Given this list of marker genes Gm14379, Ebp, Gm15257, Ssxb8, Gm26401, Maoa, Usp27x, Ssxb16, Cybb, Hdac6, B630019K06Rik, Gm9429, Gm14375, Gm14367, Sytl5, Gm14635, Rpl22-ps1, A230072C01Rik, Gm15256, Gm14504, Gm14883, Btbd35f27, Otc, Cypt1, Gata1, Csnk2a1-ps2, Gm15252, H2al1k, Gm9434, H2al1g (H2A histone family member L1G), Gm14509, Mir221, Cacna1f, Gm9436, Llph-ps2, Gm14349, Gm14370, Fthl17f, Suv39h1, Gm14485, Gm15028, Mycs, Gm6923, Timm17b, Gm5380, Gm14348, Gm14516, Gpkow, Gm14513, Smt3h2-ps, H2ap, Gm14864, Gm6798, Gm14530, 2010308F09Rik, Flicr, Ppp1r3f, H2al1j (H2A histone family member L1J), Gm6797, Fthl17-ps1, Fthl17b, Btbd35f7, Gpr82, Gpr34 (NCBI Gene Id 23890), Usp11, Ssxa1, Gm23628, Gm14450, H2al1h, Mir222, Gm16481 (NCBI Gene Id 675380), Atp6ap2, Gm22783, Gm5123, Spin2-ps9, Mid1ip1, Mir188, Gm14520, Ccdc22, Nudt10, Plp2, Was, Kcnd1, Gm14538, Dusp21, Rpl36-ps10, Gm14365, Gm25481, Ssxb10, Shroom4, Slc38a5, Wdr13, Gm5383, Ssxb6, Kdm6a (lysine (K)-specific demethylase 6A), Gm14529, AA414768, Otud5 (NCBI Gene Id 54644), Gm14531, Gm9428, Zfp182, Gm14380, Praf2, Dipk2b, Gm14491, H2al1i, Gm9427, Rbm3, Bmp15, Btbd35f4, Psmb6-ps, Fthl17c, Gm5752, Ndp, Gm14355, Gm14448, Mir501, Gm14352, Rpl3-ps1, Gm4984 (NCBI Gene Id 245347), Gm14518, Drr1, H2al3, 5730405O15Rik, Dgkk, Gm14539, Ssxb3, Mir500, Rbm3os, Rpl23a-ps13, Mir1198, Gm14361, Gm14332, H2al1d, Ftsj1, Ccnb3, Gm14333, Slc35a2, Gm14506, H2al1n, Spin2-ps1, Gm14362, Gm14634, Btbd35f20, 4930402K13Rik, Gm14862, Gm9432, H2al1b (NCBI Gene Id 100042927), Gm16480, Gm5755, Cfp, Gm4725, Gm9431, Araf, Fthl17-ps2, Uba1, Gm14510 (NCBI Gene Id 331380), 4933416E14Rik, Ssxb13, Spaca5, Mir362, Gm9430, Gm6079, Gm14470, Ddx3x, Btbd35f10, Gm9083, Zfp300, Fthl17e, Btbd35f17, Gm1848, Ssxb5, 2010204K13Rik (RIKEN cDNA 2010204K13 gene), Gm14521 (predicted gene 14521), Gm14366, Rgn, Gm5754, Ezhip, Magix, Ssxb15, Fthl17-ps3, Rpl19-ps12, Rpgr (NCBI Gene Id 19893), H2al1m, Gm14503, Foxp3, Ssxb14, Ccdc120, Pim2, Gm14357, 1810030O07Rik, Gm26314, Lancl3, Gm5384, Uxt, Maob, Gm14537, Clcn5, Gm14517, Xk, Btbd35f3, Slc9a7, Gm6829, Glod5, Rbm10, Cdk16, Elk1, Porcn (porcupine O-acyltransferase), Srpx, Tbc1d25, Nyx, Gm5381, Gm5925, Gm4726, Usp9x (ubiquitin specific peptidase 9, X chromosome), Btbd35f16 (BTB domain containing 35, family member 16), Ndufb11, Gm7079, Gm14502, Tfe3, Gm14480, Syp, Chst7, Gm25202, Fundc1, Gm5924, Gm14703, Gm7129, Ssxb9, H2al1a, Pqbp1, Gm14373, Gm14519, Gm14457, Pcsk1n, Btbd35f28, Cask, Gm5379, Gm5073, Gm6019, Bcor, Rp2, Fthl17d, Dynlt3, Gm14885, Btbd35f11, Gm14356, Syn1, H2al1f, Mir532, Gm5931, Nudt11, Gm9435, Gm14451, Gm14473, Ssxb2, Wdr45, Psmb7-ps2 (proteasome (prosome, macropain) subunit, beta type 7, pseudogene 2), n-R5s2, Gm14350, Ssxb1, Gm14514, Jade3, Gm16479, Rpl30-ps11, Gripap1, Tspan7, Gm14353, Eras, Gm15260, H2al1e, Mir5617, Med14, Gm14395, Gm14334, Gm25728, Timp1, Akap4, Gm9085, Btbd35f18, Prickle3, Gm26618, Gm6787, Gm39500, Btbd35f24, Gm25552, Tex13c3, Gm14452, H2al1c, Efhc2 (EF-hand domain (C-terminal) containing 2), Gm14865, H2al1o, Gm14534, Gm23082, here is a description of the gene set: studied in species Mus musculus Mouse Gene Set: chrXA1